The following is a description of a gene set: Mouse Gene Set: REACTOME_CELL_CELL_COMMUNICATION studied in species Mus musculus Cell-Cell communication, and this is the list of marker genes: F11r (NCBI Gene Id 226655), Cadm2, Rsu1, Ang, Nck2, Arhgef6, Itgb1, Fblim1, Fermt2, Gm5150, Hoxc8, Pvr, Pard6g, Itga6, Ctnna1, Skap2, Angptl4, Parva, Adam19, Zeb2, Sftpa1, Adam33, Flna, Sirpb1b, Kirrel2, Nphs1, Pard3, Cd47, Cdh9, Cadm3, Ilk, Nck1, Lims2, Nectin3, Actg1, Cadm1, Krt5, Ctnnb1, Dst, Cdh4, Cdh11, Sp1, Tyrobp, Prkci, Afdn (NCBI Gene Id 240024), Ctnnd1, Grb2, Sdk1, Fyn, Pxn, Actn1, Cdh12, Kirrel1, Cd151, Jup, Cdh15 (NCBI Gene Id 12555), Plec, Cdh2, Nphs2, Sirpd, Cdh7, Iqgap1, Fyb1, Cdh10, Nectin1, Cdh3, Col17a1, Ilf3, Vasp, Itgb4, Lims1, Cdh5, Cdh24, Ptk2b, Parvb, Cdh13, Cdh8, Sirpb1a, Cdh6, Nectin4, Sdk2, Kirrel3, Megf6, Krt14, Actb, Sftpd, Nectin2, Tesk1, Cdh18, Flnc, Sirpa, Pard6b, Sirpb1c, Pard6a, Cdh17, Amot